Given this list of marker genes HOGA1, ANXA4, LRRC27, SPATA41, UGT2B4, UGT2B17, FAHD2A, FOXH1, CRAT, CYP11B1, USP43, ST6GALNAC6, OPLAH, CIMAP1D, DOK3, F7, NEK11, PARP2, ZC3HC1, TSPAN11, RNF123, GLYATL1, LINC00474, FLRT1, GAP43, MEG3, SLC28A3, TLCD1, ZNF804B, DCDC2B, GRK4, CMAS, ZNF208, AP4M1, STUM, TREML2, KLF17P1 (NCBI Gene Id 100133321), TAB1, CD80, ZBED1, PDZD2, CCK, GCNT4, CD1D, PLD2, USP49, ITGA10, TDO2, TMPRSS3, KIAA1549, ALOX12, TYRP1, ELMOD1, PHTF1, ZFPL1 (NCBI Gene Id 7542), LHFPL4, HSPA1L, GEMIN5, GPX8, KIF22, GLIS2, CELSR2, NUTM1, MUCL1, BOD1L2, CYB5R3, ZC2HC1C (NCBI Gene Id 79696), TMEM238L, MC1R, KRBA2, CAB39L, FARP2, HOXB1, TBC1D27P, DDX41, CYP2C8, VWA1, IRF3, IRGC, CYP4F8, PTGIS, ZNF784, GTSF1L, PAK6-AS1, ENSG00000258422, ADH7, DAAM2, ZBTB44-DT, LINC02880, ZNF787, BANK1, CAV1, FAM238C, CALHM2, HSPA12A, ASB17, LPA, ZNF461, ADAMTS14, TIGD6, GATB, EMD, C1QTNF4 (NCBI Gene Id 83846), QTRT1, AGER, BIN1, DSCR4, GIGYF1, TMEM219, THBS3, TBX4, SH3GL3, SLC38A7, RAB35, MIIP, SLC52A2, SPATA3-AS1, ABCD1, COPG2, FAM170B, MAPRE3, NPRL3, LMO2, ZMYND19, FCSK, TOLLIP-DT, MARK4, MCF2L2, RECQL5, CCDC68, TMEM132C, RALY, SORBS3, THAP7-AS1, DPH2, E2F1, GPR137, SPAM1, ZNF771, MYO1D, EOLA2-DT, CRLS1, STRN4, GGT1 (NCBI Gene Id 91347), RSU1P2, LMCD1, PCAT19, KHDC1, ACTL7A, SPATA9, OR3A2, HTT, CDH19 (cadherin 19), KRT8P12, TNFRSF11A, RASL12, ITLN1, PCDH9, MUC4, RHBDF2, UBXN11, MIXL1, SELENOO, LINC00477, PLPPR2, FOXS1 (forkhead box S1), SPRYD3, POMGNT2, NTS, DYNC1I1, BPIFC, MYO5B, DZIP1, FZD7, SLC44A5, MAGEB6, ADGRL4, SLITRK1, ZNF252P-AS1, TMEM171, RHBDL3, SIRT2, PRND, TSPAN7 (NCBI Gene Id 7102), TAS2R50, PSKH1, GHDC, TCF12-DT, CPSF4, ITGA5, FNDC9, C3orf36, FLG2, MAN2C1, here is a description of the gene set: Human CD14 positive monocytes were purified from healthy volunteers’ blood and cultured in vitro for 4, 12, 24, 72 hours. While culturing, macrophages were activated alternatively with interleukin-4 (IL-4 100 ng/ml) or classically with interferon-gamma (IFNg 100 ng/ml)+tumor necrosis factor (TNF 50 ng/ml) or left without activation. Simultaneously, macrophages were also treated with vehicle (DMSO:ethanol) or 1mM synthetic PPARg agonist, Rosiglitazone. We used Affymetrix microarrays (U133Plus 2.0) to analyze activation and PPARg-induced gene expression changes. from publication Szanto A, Balint BL, Nagy ZS, Barta E, Dezso B, Pap A, Szeles L, Poliska S, Oros M, Evans RM, Barak Y, Schwabe J, Nagy L (PMID 21093321) Human Gene Set: GSE16385_UNTREATED_VS_12H_IFNG_TNF_TREATED_MACROPHAGE_UP Genes up-regulated in macrophages (12h): control versus IFNG and TNF. studied in species Homo sapiens